Given this list of marker genes Nlrc5, Fcer1g (NCBI Gene Id 98395), Ifi209, Ccnd2, Plac8, Dusp7 (dual specificity phosphatase 7), Vim, Bcl3, H2-T23, Phf11b, Calm1, Ccnd1, Trp53i11, Tomm70a, Fdps, Actr3, Sdc3, Naa20, Hnrnpab, Xrn1, Hmgcs1, Igtp, Pmepa1, Derl2, Samd9l, Evi2a, Plaur, Ifi211, Kif5b, Eif5a, Frmd4a, Cnp, Arf4, Gramd2b, Samhd1 (NCBI Gene Id 56045), Herc6, Daxx, Atg3, Sgcb (NCBI Gene Id 24051), Jaml, Cacybp, Igkc, Gtf3c6, Spcs2, Nmi, Selenow, Cxcl9, C1galt1c1, Tnpo3, Usp25, Srsf3, Helz2, Ddx39a, Sema4d, Marchf5, Cope, Dnaja2, Gbp7, Ell2, Psma2, Hspa8, Ndufv2, Ly6a, Rnase6 (NCBI Gene Id 78416), Rnf213, Gng12, Ly6d, Flot1, Phf11a (NCBI Gene Id 71191), Socs1, Snx2, Cd82, Tpm3, Gpx4, Pfn1, Pnp, Hivep3, Atp1b3, Gtpbp4, Stat2, Eif2ak2, Sct, Acadl, Ranbp2, Coq2, Etv6, Scarb2, Pirb, Eepd1, Ppp2ca, Jak2, Rap1a, Pttg1, Ptprc, Trim30d, Lgals3bp, H2-Q7, Cd38, Edem1, Pkib, Ifi47 (interferon gamma inducible protein 47), Cd164, Themis2, Atp2b4 (NCBI Gene Id 381290), Tmed5, Treml2 (triggering receptor expressed on myeloid cells-like 2), Slfn5, Trim30a, Armcx3, Emp3, Carmil1, Adar, Zfp217, Phf6, Lyst, Cycs, Tagap, Birc3, Gadd45b, Gpr65, Atp6v1d, Trafd1, Sf1, Pfkp, Irf7, Msmo1, Znfx1, Dnajc7, Reep3 (NCBI Gene Id 28193), H2-T22, Gbp4, Lrp8, Tpm4, Tspo, Cbfa2t3, Csf2rb, Stat1, Cdkn2d, Sumo1, Chd1, Fnbp4, Pgam2 (phosphoglycerate mutase 2), Tor1aip1, Rwdd1, Ptpn1, Cited2, Sdc4, Trim30b, Phyh, Lcp1, Isg15, Nt5c3, Ifi207, Mlx, Snf8, Idi1, Ube2l6, Eif1, Srsf7, Slc15a3, Tap1, Ifitm3, Tor3a, Ppp3cb, Nampt, Phf11d, Parp14, Dbnl, Dhx58 (NCBI Gene Id 93832), Ms4a4c, Ifi203, Casp4, Tagln2, Rnh1, Bcl11a, Csf2rb2, Apod, Ifi213 (NCBI Gene Id 623121), Mndal, Isg20, Bbx, Ifi204, Ccnd3, Zbp1, Ifit2, Calhm6, Sting1, Clec2d, Map3k8, Edem2, Epha2, Lgals9, Cdc42, Fads3, Srsf5, Arpc5, Ldlr, Kdr, Sp100, Ppa1, Tap2, Smarca5, Ly6c2, Fam241a, Iigp1, Psme2, Fndc3a, Napsa (NCBI Gene Id 16541), Scimp (SLP adaptor and CSK interacting membrane protein), Anxa6, Ikzf2, Psmb5, Oasl2, Mat2a, Serpina3g, Pml (NCBI Gene Id 338524), Sp110, Trim12c, Usp18, Iqgap1, Grb2, Psmb6, Tuba1b, Irf1, Ppp1r11, P2ry13, Tcstv4, Hck, Dynll1, Pim1, Il4ra, Cfl1, Il21r, Arf1, Tespa1, Rbm8a, Nrros, Parp9, Eloc, Cdh1, Hspa5, Armcx6, Mgat1, Irgm1, Strap, Socs3, Actr2, Slc25a22, Srsf2, Rsad2, B4galt5, Dnajb11, Nceh1, Shisa5, Sh3bp2, Dnaja1, Psmb9 (NCBI Gene Id 16912), Larp1, Ifi35, Mx1, Ifi27l2a, Acer3, Actg1, Ptms, Xaf1, P2ry14, Oasl1, Itpr1, Slfn2, Ifi44, Ifih1, H2-K1, here is a description of the gene set: Cytokines mediate cell-cell communication in the immune system and represent important therapeutic targets. A myriad of studies have highlighted their central role in immune function, yet we lack a global view of the cellular responses of each immune cell type to each cytokine. To address this gap, the authors created the Immune Dictionary, a compendium of single-cell transcriptomic profiles of more than 17 immune cell types in response to each of 86 cytokines (>1,400 cytokine-cell type combinations) in mouse lymph nodes in vivo. A cytokine-centric view of the dictionary revealed that most cytokines induce highly cell-type-specific responses. For example, the inflammatory cytokine interleukin-1β induces distinct gene programmes in almost every cell type. A cell-type-centric view of the dictionary identified more than 66 cytokine-driven cellular polarization states across immune cell types, including previously uncharacterized states such as an interleukin-18-induced polyfunctional natural killer cell state. studied in species Mus musculus from publication Cui A, Huang T, Li S, Ma A, Pérez JL, Sander C, Keskin DB, Wu CJ, Fraenkel E, Hacohen N (PMID 38057668) Mouse Gene Set: CUI_PDC_IL15_RESPONSE_UP Genes positively differentially expressed in cell type: pDC (plasmacytoid dendritic cell) upon treatment with cytokine: IL-15 in mouse lymph nodes in vivo.